The following is a description of a gene set: studied in species Homo sapiens The acetylation of peptidyl-lysine. Human Gene Set: GOBP_PEPTIDYL_LYSINE_ACETYLATION, and this is the list of marker genes: KLF15, KAT2B, EP300, NAT8, SIRT1, DIP2A, ATAT1, DIP2B, BLOC1S1, KAT7, BAG6 (NCBI Gene Id 7917), KAT2A, NAT8B, ESCO1, CREBBP, KAT5